The following is a description of a gene set: from publication Chen Y, Wang X (PMID 31504780) Human Gene Set: MIR891A_3P Genes predicted to be targets of miRBase v22 microRNA hsa-miR-891a-3p in miRDB v6.0 with MirTarget v4 prediction scores > 80 (high confidence targets). studied in species Homo sapiens, and this is the list of marker genes: PBX1, SH3GLB1, NAV3, PTPRK, ARHGEF7, ZNF131, SCHIP1, IRX2, LIPH, TSC22D2, SRF, EDEM3, ROBO1, UBE2G1, LGALSL, ST6GALNAC4, FKTN, SESN2 (NCBI Gene Id 83667), ANKRD40, SPC25, VKORC1, CHD5, OTX1, GLIPR1L2, AFF1, CHMP7, PRRG3, EBF2, DGKZ, PHACTR2, BTD, RTN3 (reticulon 3), PARP12, MAPK13, RGL1, CEP120, ZNF827, NLGN4Y (neuroligin 4 Y-linked), PTPDC1, MLLT10, VDAC3, KPNA3, YBX2, CUL5, HIGD2A, ACVR1B, GALNT1, SRSF6, MEOX2, AKAP13, IQCJ-SCHIP1, NRBF2, ASPH, SFPQ, SMURF1, KLB, FBXO40, AP3M1, NRAS, SPRY3, SGIP1, SYTL2, MAPK1, COL11A1 (NCBI Gene Id 317718), SLK, ACER3, PJVK, RBM20, RARRES1, PPP1R12A, APPBP2, HECA, TEX2, CTNNB1, PDZRN4, RBFA, FGF5, EPHA7, PDXDC1, FLT1, WHRN, GALNT16, KDM7A, TES, COBL, SCN1A, HYOU1, SPTLC1, TRPM3, FOS, FLNC, EEA1, CUL2, PPP3CA, GIMAP6, SFTPA2, XKR9, PRPF40A (pre-mRNA processing factor 40 homolog A), CREBRF, LRAT, MSL2, SLC17A6, WASF3, RBMS1, TGFBR1, PTPN12, SLC9A4, TSFM, CPOX, PHF20, CADM2 (cell adhesion molecule 2), GALK2, MYOZ2, RNF144A, PLTP, TMED4, ADSS2, ABL1, EPB41L1, ABTB3, NLGN4X, FNDC3A, NFIB, FBXO45, PARP8, ALDH5A1, UBE2B